Given this list of marker genes TP63, WDR26 (NCBI Gene Id 80232), MSX1, IRF6, NECTIN1, here is a description of the gene set: studied in species Homo sapiens Human Gene Set: HP_ABNORMAL_EUSTACHIAN_TUBE_MORPHOLOGY Abnormal Eustachian tube morphology A structural anomaly of the Eustachian tube (ET). The ET is a biomechanical valve between the nasopharynx and the middle ear. Physiologically, it controls the passive adaptation of the middle ear air pressure to the ambient air pressure primarily via direct muscular actions of the soft palate. In the closed state it protects the middle ear. Inadequate function of the ET causes middle ear ventilation disorders.